The following is a description of a gene set: Cytokines mediate cell-cell communication in the immune system and represent important therapeutic targets. A myriad of studies have highlighted their central role in immune function, yet we lack a global view of the cellular responses of each immune cell type to each cytokine. To address this gap, the authors created the Immune Dictionary, a compendium of single-cell transcriptomic profiles of more than 17 immune cell types in response to each of 86 cytokines (>1,400 cytokine-cell type combinations) in mouse lymph nodes in vivo. A cytokine-centric view of the dictionary revealed that most cytokines induce highly cell-type-specific responses. For example, the inflammatory cytokine interleukin-1β induces distinct gene programmes in almost every cell type. A cell-type-centric view of the dictionary identified more than 66 cytokine-driven cellular polarization states across immune cell types, including previously uncharacterized states such as an interleukin-18-induced polyfunctional natural killer cell state. Mouse Gene Set: CUI_T_CELL_CD4_IL2_RESPONSE_UP species: Mus musculus Genes positively differentially expressed in cell type: CD4+ T cell upon treatment with cytokine: IL-2 in mouse lymph nodes in vivo. from publication Cui A, Huang T, Li S, Ma A, Pérez JL, Sander C, Keskin DB, Wu CJ, Fraenkel E, Hacohen N (PMID 38057668), and this is the list of marker genes: Igtp, Igfbp4, Tapbpl, Gbp5, Psmb9, Dtx3l, Pfn1, Stat3, Irf8, Tap1, Gimap4, Apobec3, Eif5a, H2-T23, Tpr, Tuba4a, Rtp4, Tap2, B2m, Cycs, Rapgef6, Psmb10, Irf1 (NCBI Gene Id 16362), Esyt1, Tpm3, Psme1, Iigp1, Ppa1, Irgm2, H2-T22, Ly6e, Eeig1, Kbtbd11, Tapbp, Cd274, Trim56, Sbno2, Gbp7, Socs1, Ly6a, Psmb8 (NCBI Gene Id 16913), Ifi203, Abtb2, Nfkb1, Irf9, Gbp9, Ifi47, Mllt6, Srsf6, Stat1, Ldha, Psme2, Gbp4, Casp8, Cdk4, Bst2, Zbp1, Bcl3, Gbp8, Arid5b, Mthfd2, Hsp90b1, Slfn5, Calhm6, Parp9, Parp14, Ccnd2, Tuba1b, Nlrc5, Notch1, Gbp2 (NCBI Gene Id 14469), Socs3, Icam1, Xaf1, Actg1, Samhd1, Rnf114, Irgm1, Rexo2, Agfg1, Adar